Given this list of marker genes SHLD1, CLCF1, FOXP3, EXOSC3, SHLD3, MAD2L2, RIF1, SHLD2, IL2, IL4, HMCES, SUPT6H, CD40, TFRC, TNFSF13, KMT5B (lysine methyltransferase 5B), PARP3, TBX21, IL10, ATAD5, EXOSC6, STAT6, TNFSF4, PAXIP1, SLC15A4, TGFB1, BCL6, CD28, PMS2, NSD2, MLH1, APLF, IL27RA, TP53BP1, KMT5C, PTPRC, NDFIP1, MSH2, here is a description of the gene set: species: Homo sapiens Any process that modulates the frequency, rate or extent of isotype switching. Human Gene Set: GOBP_REGULATION_OF_ISOTYPE_SWITCHING